The following is a description of a gene set: Mouse Gene Set: GOBP_CELLULAR_RESPONSE_TO_DEXAMETHASONE_STIMULUS species: Mus musculus Any process that results in a change in state or activity of a cell (in terms of movement, secretion, enzyme production, gene expression, etc.) as a result of a dexamethasone stimulus., and this is the list of marker genes: Tgfb1, Foxo1, Eif4ebp1, Nr3c1, Star, Eif4e, Hnrnpu, Ifnb1, Jak2, Axin2, Rps6kb1, Fech, Abcb1a, Ddit4, Agtr1a, Ass1, Mstn, Serpinf1, Crh, Fbxo32, Gdnf, Agtr2, Smyd3, Mir155, Atp5f1a, Mir21a, Trim63, Agtr1b, Mettl21c, Pck1, Aqp1, Bmi1, Casp9, Tbx2, Bmp4, Egfr, Ccl2, Pck2, Gjb2